Given this list of marker genes ABCG2, UROD (NCBI Gene Id 7389), ALAS2, ALAS1, FECH, COX10, UROS, COX15, FLVCR1, HMBS, PPOX, CPOX, ALAD, ALB, here is a description of the gene set: Human Gene Set: REACTOME_HEME_BIOSYNTHESIS studied in species Homo sapiens Heme biosynthesis